The following is a description of a gene set: from publication Gaussmann A, Wenger T, Eberle I, Bursen A, Bracharz S, Herr I, Dingermann T, Marschalek R (PMID 17130830) Mouse Gene Set: GAUSSMANN_MLL_AF4_FUSION_TARGETS_C_UP The reciprocal chromosomal translocation t(4;11) is correlated with infant, childhood, adult and therapy-related high-risk acute leukemia. Here, we investigated the biological effects of MLL.AF4, AF4.MLL or the combination of both reciprocal fusion proteins in a conditional in vitro cell culture model system. Several parameters like cell growth, cell cycling capacity, apoptotic behavior and growth transformation were investigated under physiological and stress conditions. Co-transfected cells displayed the highest resistance against apoptotic triggers, cell cycling capacity and loss-of-contact inhibition. These analyses were complemented by gene expression profiling experiments and specific gene signatures were established for each of the three cell lines. Interestingly, co-transfected cells strongly upregulate the homeobox gene Nanog. In combination with Oct4, the Nanog homeoprotein is steering maintenance of pluripotency and self-renewal in embryonic stem cells. Transcription of Nanog and other stem cell factors, like Oct4 and Bmi1, was verified in biopsy material of t(4;11) patient cells which express both reciprocal t(4;11) fusion genes. In conclusion, the presence of both reciprocal MLL fusion proteins confers biological properties known from t(4;11) leukemia, suggesting that each of the two fusion proteins contribute specific properties and, in combination, also synergistic effects to the leukemic phenotype. studied in species Mus musculus Up-regulated genes from the set C (Fig. 5a): specific to cells expressing AF4-MLL fusion protein alone., and this is the list of marker genes: Flt4, Sh3bgrl2, Ggnbp2 (NCBI Gene Id 97681), ENSMUSG00000133985, Nek7, Rora, Fkbp14, 4933430A20Rik, Col27a1, 2500004C02Rik, Cldn10, Usp3, Neto2, Fgd3, Nes, Kctd3, Sacm1l, Ergic2, Crybg1, Lrch1, Ppp1r13b, Prpf4b, Lrrc63, Map4k5, Nfkbie, Neurod1, Itga1, Kank3 (KN motif and ankyrin repeat domains 3), Rfx3, Prpf40b, Speg, Tnfrsf19, Timp3, Cxcl10, Glis3, Calu, Car9, Yipf4, Mir22hg, Ifitm1, Mrps15, Bnip2, Prkag1, Pabpc2, Pde1c, Col5a1, Nxn, Fam149a, Phip, Ppp1r16a, Cotl1, Ddah1, Fbxl3, Plec, Hspa1a, Cgas, Per1, Smr2, Trpm5, Chmp5, 5530601H04Rik, Sox7, Erbin, Scrn3, Dnajc3, Dpy19l3, Fat4, Malat1, Zic3, Yipf2, Pthlh, Tll1, Tpk1, Mir100hg, Castor2, Rab3il1, Rps6ka5, B3gat3, Lfng, Nck1, Lrig1, 4930543N07Rik, Pdlim5, Tcf4, Rps15a, Tcl1b4, Tomm20, Slc11a2, Emc7, Msln, Csnk1a1, Macroh2a2, Psmd7, Rbm10, Meox1, Bub3, Ier5l, Dmp1, Pdzd2, Mxra7, Prpf38b, Brd2, Tent2, Rmnd1, Unc13b, Cdc42ep2, Ptprd, Foxn3, Wdr6, Zfp182, Tcf7, E2f6, Actn3, Acaa1a, Tmc6, Pdcd6ip, Txlnb, Rps20, Slc12a6, Fam13c, Dnmt3a (DNA methyltransferase 3A), Pld3, Klf12, Ccdc125 (coiled-coil domain containing 125), Nemf, Ube2d3, Pik3ca, Mettl27, Dapp1, Zbtb38, Gpr45, Rbm3os, Zmat2, Nherf2, Rasl12, Btf3l4, Ctsf, Map3k1, Brdt (bromodomain, testis-specific), Mfsd8, Tsnaxip1, Nktr, Ecrg4, Fndc3a, Gpsm1, H2bc22, Alg14, B3galt1, Lcorl, Ifitm3, Fam20a, Stag1, 4732496C06Rik, Ifnar1, Plau, Ino80 (NCBI Gene Id 76476, INO80 complex subunit), B4galnt1, Rassf3, Trp73, Fkbp7, Tec, Zc3h11a, Ugdh, Puf60, Ppp1r3f, Ccar1, Hypk, Srsf11, Cox11, Sdc1, Tubg2, Snx13, Stat3, Ywhaz, Lacc1, Rreb1, Rprd2, Cpt1a, Lysmd1, Lpin1, Map2k4, Nedd9